Given this list of marker genes Bmp7, Crp (C-reactive protein, pentraxin-related), Bmp5 (NCBI Gene Id 12160), Elavl4, Zdhhc15, Abl1, Vldlr, Pacsin1, Lrp8, Dab2ip, Tmem106b, Alk, Opa1, Clip1, Ptprz1, Crtc1, Khdc3 (NCBI Gene Id 66991), Iqgap1, Ptn, Cobl, Cyfip1 (NCBI Gene Id 29878), Ezh2, here is a description of the gene set: Any process that activates or increases the frequency, rate or extent of dendrite development. Mouse Gene Set: GOBP_POSITIVE_REGULATION_OF_DENDRITE_DEVELOPMENT studied in species Mus musculus